Given this list of marker genes AKR7A2, EPHX1, CYP3A4, CYP1A2, GSTM1, AKR7A3, CYP2A13, here is a description of the gene set: Aflatoxin B1 metabolism species: Homo sapiens Human Gene Set: WP_AFLATOXIN_B1_METABOLISM